Given this list of marker genes POLD3, USP1, RPA3, POLE4, POLD1, RPA1, RPS27A, DDB1, UBC, RFC2, DTL, RFC4 (NCBI Gene Id 5984), UBE2B, RBX1, UBA52, RFC1, CUL4B, UBB, CUL4A, RAD18, POLE3, RFC5, POLD2, POLD4, POLE2, WDR48, RPA2, RFC3, PCNA, POLE, here is a description of the gene set: Human Gene Set: REACTOME_RECOGNITION_OF_DNA_DAMAGE_BY_PCNA_CONTAINING_REPLICATION_COMPLEX species: Homo sapiens Recognition of DNA damage by PCNA-containing replication complex